Given this list of marker genes SLC7A11, EHD4, SOCS2, PLAU, GABPB1, AKAP12, TGFA, GPN2, HERPUD1, STK17A (NCBI Gene Id 9263), PTAFR, PCDH7, PTHLH, MICAL2, DUSP4 (dual specificity phosphatase 4), TNFRSF12A, B3GNT2, ITSN1, INSIG1, BMP2, TUBB2A, here is a description of the gene set: from publication Amit I, Citri A, Shay T, Lu Y, Katz M, Zhang F, Tarcic G, Siwak D, Lahad J, Jacob-Hirsch J, Amariglio N, Vaisman N, Segal E, Rechavi G, Alon U, Mills GB, Domany E, Yarden Y (PMID 17322878) Human Gene Set: AMIT_EGF_RESPONSE_240_MCF10A Genes whose expression peaked at 240 min after stimulation of MCF10A cells with EGF. Signaling pathways invoke interplays between forward signaling and feedback to drive robust cellular response. In this study, we address the dynamics of growth factor signaling through profiling of protein phosphorylation and gene expression, demonstrating the presence of a kinetically defined cluster of delayed early genes that function to attenuate the early events of growth factor signaling. Using epidermal growth factor receptor signaling as the major model system and concentrating on regulation of transcription and mRNA stability, we demonstrate that a number of genes within the delayed early gene cluster function as feedback regulators of immediate early genes. Consistent with their role in negative regulation of cell signaling, genes within this cluster are downregulated in diverse tumor types, in correlation with clinical outcome. More generally, our study proposes a mechanistic description of the cellular response to growth factors by defining architectural motifs that underlie the function of signaling networks. species: Homo sapiens